Given this list of marker genes SLC35B2, SLC17A9, SLC25A6, ABCC5, ABCC11, SLC25A24, SLC25A53, SLC25A52, SLC25A42, ANKH, SLC25A4, SLC25A23 (NCBI Gene Id 79085), SLC25A5, LRRC8A, SLC25A51 (solute carrier family 25 member 51), SLC25A41, SLC46A2, SLC35B1, SLC25A25, ABCC4, SLC25A31, SLC19A1, SLC25A17, SLC35B3, PANX1, SLC25A47, here is a description of the gene set: Enables the transfer of a purine nucleotide, any compound consisting of a purine nucleoside esterified with (ortho)phosphate, from one side of a membrane to the other. Human Gene Set: GOMF_PURINE_NUCLEOTIDE_TRANSMEMBRANE_TRANSPORTER_ACTIVITY studied in species Homo sapiens